The following is a description of a gene set: Human Gene Set: GOMF_G_PROTEIN_BETA_GAMMA_SUBUNIT_COMPLEX_BINDING studied in species Homo sapiens Binding to a complex of G-protein beta/gamma subunits., and this is the list of marker genes: GNAZ, GNAT1, GNAS, ADORA1, CETN1, GNAT2, GNAI2, GNA11, GNAT3, GNAI1, GNA13, GNA15, TRPM3, GNAI3, GNA14, PLCB2, GNAQ (NCBI Gene Id 2776), CETN3, CETN2, GNAL (G protein subunit alpha L), GNA12, GNAO1, PIK3R5